The following is a description of a gene set: Mouse Gene Set: GOMF_VITAMIN_TRANSMEMBRANE_TRANSPORTER_ACTIVITY studied in species Mus musculus Enables the transfer of a vitamin from one side of a membrane to the other., and this is the list of marker genes: Abcg2, Slc22a1, Slc2a2, Abcd4, Slc22a14, Slc47a1, Slc2a3, Slc27a1, Slc22a2, Slc52a2, Slc19a3, Slc46a1, Pdpn, Slc19a2, Slc23a1, Slc47a2, Slc25a19, Stra6, Rbp4, Abcg3, Slc25a32, Gc, Slc52a3, Stra6l, Rtbdn, Slc23a2, Slc19a1, Slc2a1, Abcc1, Slc44a4, Slc5a6, Slc2a10, Slc2a8